Given this list of marker genes ACTA1, CRABP1, SCGB2A2, UGT2B15, TSPAN8, CXADR, EGR3, ID1, NMI, SELENOP, B2M, BCAS1, NRIP1, ANG, EIF2AK2, TUSC3, DECR1, RNASE4, E2F1, MX1, IRF9, CACNB3 (calcium voltage-gated channel auxiliary subunit beta 3), PITX1, CPE, EPHX1, NNAT, CTSD, ISG15, TAGLN, PTK6, PPP2R2A, ID3, EBAG9 (NCBI Gene Id 9166), IFITM1, IFITM3, TSPAN3, IRF2, BTG3, TFF3, GTF2E2, SEPHS2, NMT1, IFI27, TFF1, IFI44, BST2 (bone marrow stromal cell antigen 2), IFIT1, PROCR, SNX1, LGALS3BP, ARL4A, TFPI2, IFI6, GAGE13, here is a description of the gene set: species: Homo sapiens Human Gene Set: BECKER_TAMOXIFEN_RESISTANCE_UP from publication Becker M, Sommer A, Krätzschmar JR, Seidel H, Pohlenz HD, Fichtner I (PMID 15657362) Genes up-regulated in a breast cancer cell line resistant to tamoxifen compared to the parental line sensitive to the drug. The reasons why human mammary tumors become resistant to tamoxifen therapy are mainly unknown. Changes in gene expression may occur as cells acquire resistance to antiestrogens. We therefore undertook a comparative gene expression analysis of tamoxifen-sensitive and tamoxifen-resistant human breast cancer in vivo models using Affymetrix oligonucleotide arrays to analyze differential gene expression. Total RNAs from the tamoxifen-sensitive patient-derived mammary carcinoma xenograft MaCa 3366 and the tamoxifen-resistant model MaCa 3366/TAM were hybridized to Affymetrix HuGeneFL and to Hu95Av2 arrays. Pairwise comparisons and clustering algorithms were applied to identify differentially expressed genes and patterns of gene expression. As revealed by cluster analysis, the tamoxifen-sensitive and the tamoxifen-resistant breast carcinomas differed regarding their gene expression pattern. More than 100 transcripts are changed in abundance in MaCa 3366/TAM as compared with MaCa 3366. Among the genes that are differentially expressed in the tamoxifen-resistant tumors, there are several IFN-inducible and estrogen-responsive genes, and genes known to be involved in breast carcinogenesis. The genes neuronatin (NNAT) and bone marrow stem cell antigen 2 (BST2) were sharply up-regulated in MaCa 3366/TAM. The differential expression of four genes (NNAT, BST2, IGFBP5, and BCAS1) was confirmed by Taqman PCR. Our results provide the starting point for deriving markers for tamoxifen resistance by differential gene expression profiling in a human breast cancer model of acquired tamoxifen resistance. Finally, genes whose expression profiles are distinctly changed between the two xenograft lines will be further evaluated as potential targets for diagnostic or therapeutic approaches of tamoxifen-resistant breast cancer.